The following is a description of a gene set: In this study, an extensive analysis was conducted to define meta-programs (MPs) capturing intra-tumor heterogeneity across a spectrum of tumor types. The approach utilized non-negative matrix factorization (NMF) to analyze each cell type separately within individual tumor samples. This involved the analysis of malignant cells, macrophages, fibroblasts, endothelial cells, epithelial cells, T-cells, and B-cells. NMF was executed with varying parameter values (K=4, 5, 6, 7, 8, 9), thereby generating 39 programs for each cell type per sample. Each NMF program was summarized by the top genes based on NMF coefficients.\nRobust MPs were then delineated for each cell type using a set of stringent criteria, including recurrence within the same tumor, similarity to programs in other tumors, and non-redundancy within a tumor. Subsequently, these robust NMF programs were clustered (per cell type) based on Jaccard similarity, leading to the identification of MPs associated with each cell type.\nTo enhance the quality of the MPs, a refinement steps were undertaken, involving the removal of MPs suspected of reflecting low-quality data (with an overrepresentation of ribosomal proteins or mitochondrial-encoded genes), single-study inclusion, or similarity to miss-annotated cell types. from publication Gavish A, Tyler M, Greenwald AC, Hoefflin R, Simkin D, Tschernichovsky R, Galili Darnell N, Somech E, Barbolin C, Antman T, Kovarsky D, Barrett T, Gonzalez Castro LN, Halder D, Chanoch-Myers R, Laffy J, Mints M, Wider A, Tal R, Spitzer A, Hara T, Raitses-Gurevich M, Stossel C, Golan T, Tirosh A, Suvà ML, Puram SV, Tirosh I (PMID 37258682) studied in species Homo sapiens Human Gene Set: GAVISH_3CA_METAPROGRAM_CD4_T_CELLS_CELL_CYCLE Genes upregulated in subsets of cells of a given type within various tumors, and this is the list of marker genes: UBE2C, TMEM106C, H2AZ1, KPNA2, DTYMK, CCNA2, DUT, KIF22, CENPF, TMPO, TUBA1B, H4C3, TUBA1C, PHF19, CDK1, TPX2, DNAJC9, PCNA, ZWINT, ASF1B, UBE2T, MKI67, BIRC5 (baculoviral IAP repeat containing 5), NUDT1, NUSAP1, TOP2A, MAD2L1, HMGN2, CKS2, CDKN3, TK1, MCM7, PCLAF, PTTG1, CKS1B, TUBB4B, SMC2, AURKB, STMN1, CENPM, DDX39A, SMC4, HMGB2, RRM2, TUBB, FEN1, CENPW, TYMS, ASPM